The following is a description of a gene set: studied in species Homo sapiens from publication Weber BN, Chi AW, Chavez A, Yashiro-Ohtani Y, Yang Q, Shestova O, Bhandoola A (PMID 21814277) Tcf1 is necessary for optimal T lineage development. Tcf1 deficient progenitors fail to initiate the T lineage program in vitro and development is severely defective in vivo. We used microarrays to assess the overal global gene expression differences from Tcf1 wildtype and deficient lymphoid biased progenitors cultures on Notch-ligand expressing stroma to determine if Tcf1 deficient progenitors are able to intiate the T lineage specification program. Abstract of manuscript: The thymus imposes the T cell fate on incoming multipotent progenitors, but the molecular mechanisms are poorly understood. We show that transcription factor Tcf1 initiates T-lineage-specific gene expression. Tcf1 is downstream of Notch1 signaling and expressed in early T-cell progenitors. Progenitors deficient for Tcf1 are unable to initiate normal T-lineage specification. Conversely, ectopic expression of Tcf1 in hematopoietic progenitors is sufficient to induce expression of T-lineage specific genes in vitro. Thus, our study identifies Tcf1 as critically involved in the establishment T cell identity. Human Gene Set: GSE26559_TCF1_KO_VS_WT_LIN_NEG_CELL_UP Genes up-regulated in lin- cells: TCF7 knockout versus wildtype., and this is the list of marker genes: CRIP1, MARCKSL1, SUSD6, IL10RA, PKIA, SLC39A14, BLTP2, GUCY1A1, LRRN3, SMAD5, NUP50, MLF2, PLAA, MARCKS, RRAGD, NINL, CAMK1, PLK3, HCFC1, MRPL28, MTMR6, MICU1, DDR2, JARID2 (NCBI Gene Id 3720), CCN1, GLS, KAT6A, CLIC4, FLNA, ACSL3, RBM19, SKAP2, RANBP1, CYLD, PEBP1, IL4R, REEP5, CCL8, ARF3, TRIM38, GTF2H1, IL2RB, CSTB, MSL3, HTATIP2, KIF2A, RBM6, UCHL3, FDFT1, PMPCA, PRKAA1, SAFB2, CHEK1, GNAI1, DOK1, GATA3, TOMM40, SEC23A, RGS19, TRIP4, ELP1, SCAF11, POM121L6P, MARK3, BAZ1B (NCBI Gene Id 9031), GOLGA8A (golgin A8 family member A), ATP6V1G1, HSPA4, MICAL2, CPN2, FZD6, NFIL3, SPTBN1 (spectrin beta, non-erythrocytic 1), CSTF3, PPP2R5A, CD28, CRYBG3, DCP2, MED22, BCL2A1, YIF1A, FUBP3 (far upstream element binding protein 3), VPS35L, LRRC32, STX6, USP24, SF3A3 (splicing factor 3a subunit 3), UBE2E1 (ubiquitin conjugating enzyme E2 E1), SF3A1 (splicing factor 3a subunit 1), DAPK1, STXBP2, CBR1, MAP3K14, MEGF9, SNX3, HECTD4, PWAR5, SERPINB1, PPP2CB, HIPK1, SRGN, FHL2, STK39, USP33, CST7, RNH1, TBL3, GPNMB, NME4, SSBP2, NOP56, IL1RN, IL1A, GPR183, SMC4, LGALS8, UPP1, ABHD14A, PPIA, MSH4, ZFYVE16, FEM1B, MFHAS1, SEMA3A, SLC30A1, CSRNP2, PER2, FEZ2, SLC5A3, SNED1, ABCD3, GNPAT, MACF1, TRAM1, PIEZO1, STK17B, ATP6V0A2 (NCBI Gene Id 7854), HMMR, IL10RB, ORC5 (NCBI Gene Id 5001), TP53BP2, C5orf22, CCN6, LRRC42, BLVRB, H2BC11, PDS5A, SPINT2, WDR77, MLEC, CTSC, FBXO21 (F-box protein 21), SRPK2, AKAP9, RASA1, PEX3, EGR2, MAPK1, MICU2, BICD2, IL1R1, PECAM1, SERTAD2, CELF2, SEC24A, SMARCA1, EGR3, ACADM, TFAM, MAML1, TIAM1, MYRF, ZFP36, TSPAN3, ST8SIA4, RBM14, NAGLU, ITPA, SLF2, EXT1, AOAH, RBM42, MPHOSPH10, ICAM2, CROT, ARHGAP25, SSB, SEC23IP, SOCS1, CCNG2, RWDD3, KDELR2, CAST, EIF1B, MAP4, SRSF8, ERCC1, EFR3A